Given this list of marker genes Nme2, Nab2, Zfp36, Vdr, Macroh2a2 (NCBI Gene Id 404634), Cyp27b1, Trp63, Bmp4, Notch1, Fgf2, Sult2b1, Mycn, Mafg, Krt84, Rock1, Rock2, Cd109, Hes5, Sgpp1, Med1, Numa1, Hoxa7, Tfap2c, Grhl1, Elapor2, Zfp36l1, Hey2, Etv4, Krt2, Kdf1, Extl3, Sfn, Reg3a, Ptch2, Errfi1, Alox8, Ptch1, Tgfb2, Tmem79, Srsf6, Prkch, Fgfr3, Hey1, Dll1, Esrp1 (NCBI Gene Id 70076), Pkp1, Krt36, Reg3g, Mycl, Maff, Keap1, Foxc1, Ovol2, Krt10, Ezh2, Ncoa3, Abca12, Macroh2a1, Klf7 (NCBI Gene Id 93691), Ppard, Gdf3, Msx2, Sfrp4, Hes1, Nab1, Atoh1 (atonal bHLH transcription factor 1), here is a description of the gene set: Any process that modulates the frequency, rate or extent of epidermis development. Mouse Gene Set: GOBP_REGULATION_OF_EPIDERMIS_DEVELOPMENT species: Mus musculus